Given this list of marker genes MTMR6, PIP5K1A, PIK3CB, PIK3CG, PIK3R1, MTMR9, SYNJ2, PIK3R3, PIP4K2C, PLEKHA1, RAB4A, SYNJ1, PIP4K2B, MTMR8, PI4K2B, PIK3CD, RAB5A, PIP5K1B, SBF2, PTPN13, RAB14, MTM1, PIK3C2G, MTMR2, PLEKHA2, PIK3R5, PLEKHA5, PIK3CA, PIK3R2, PIK3C2B, PLEKHA3, BMX, MTMR1, PIK3R6, INPP5D, PTEN, PIK3C2A, ARF1, PLEKHA8, INPP4B, PLEKHA6, INPPL1, PI4K2A, INPP5K, RUFY1, PIP5K1C, MTMR3, OCRL, PLEKHA4, INPP5J, PIP4K2A, MTMR14, INPP4A, here is a description of the gene set: species: Homo sapiens Reactome Pathway: Synthesis of PIPs at the plasma membrane At the plasma membrane, subsequent phosphorylation of phosphatidylinositol 4-phosphate (PI4P) produces phosphatidylinositol 4,5-bisphosphate (PI(4,5)P2) and phosphatidylinositol 3,4,5-trisphosphate (PI(3,4,5)P3) while the actions of various other kinases and phosphatases produces phosphatidylinositol 3-phosphate (PI3P), phosphatidylinositol 5-phosphate (PI5P), phosphatidylinositol 3,4-bisphosphate (PI(3,4)P2), and phosphatidylinositol 3,5-bisphosphate (PI(3,5)P2). Many of the phosphatidylinositol phosphatases that act at the plasma membrane belong to the myotubularin family. Enzymatically inactive myotubularin family members can heterodimerize with catalytically active mytotubularins to regulate their stability, activity and/or substrate specificity. part of: PI Metabolism